Given this list of marker genes SLC35G3, VPS13D, EXOC2, GPSM2, SOBP, SLC10A7, GBP6, FCGR2A (NCBI Gene Id 90764), ANKH, MMP16, CCNT2 (cyclin T2), HRH4, PPP1R3B, LINC02898, PPP1R12B, HLA-DPB1, CCDC149, CNR1, CAMK1D, ARHGEF12, MYO5A, CRPPA, PNLIPRP3, USP49, ADAM29, MBD3, ZC3H12A, SCML4, DEPTOR, G2E3, HS3ST5 (heparan sulfate-glucosamine 3-sulfotransferase 5), ADAMTS17, ERBIN, RBM24, NECTIN4, MICAL2, SPECC1, GSE1, FREM1, APOBEC3B, HEY2, SLC35E4 (solute carrier family 35 member E4), CHRD, JADE1, CCDC62, UPF2, DRP2, DMXL1, RUFY3, NHLRC3, MASP1, DROSHA, ZZZ3, MTMR7, SYTL4, FGFBP3, MTFR1L, WDR5, here is a description of the gene set: Genes predicted to be targets of miRBase v22 microRNA hsa-miR-4522 in miRDB v6.0 with MirTarget v4 prediction scores > 80 (high confidence targets). from publication Chen Y, Wang X (PMID 31504780) Human Gene Set: MIR4522 species: Homo sapiens